Given this list of marker genes TERF2IP, CD300A, CDKN1C, LYN, TP53, DUSP7, TARBP2, PRKG1, PRKDC, RB1, PDCD4, PDGFB, SNX6, GIT1, KLHL31, DNAJC3, PTPRJ, ERRFI1, DBNDD2, STAT3, ZBED3, MVP, C9orf72, DDIT4, PARD3, RD3, AMDHD2, CDA (NCBI Gene Id 978), CEACAM1, IGFBP3, PDGFA, INPP5K, CDK5RAP1, SLC4A1, ZC3H12A, AKT1S1, VPS25, PARP1, IER3, NCOR1, WARS1, HIPK3, IQGAP1, MIR675, SOCS5, LPIN1, SFRP1, TRIM27, GSKIP, CDKN1A, SIRT2, INCA1, TFAP4, FKBP8, CORO1C, TSG101, PKIA, GMPPA, SOCS4, PRKCH, ADAR, RGS14, DYNLL1, PRR5L, DMTN, HNRNPU, CEP43, NT5DC2, PID1, SMO, HDAC4, YWHAG, RASIP1, PAQR3, TAF7, MACROH2A1, PTEN, PYCARD, NUPR1, INHA, CACTIN, AGT, ZGPAT, GADD45A, FBLN1, PTPRC, MAPK8IP1, EPM2A, PTPN13, ACTN3, SLIT2, PTPN22, AIDA, MEN1, PARP14, TSPO, INPP5F, GCKR, NIBAN1, TRAF3IP1, ATG14, NPPA, SFN, CHMP6 (charged multivesicular body protein 6), HEG1, CDK5RAP3, PIBF1, DEFB114, CDKN1B, SIRT1, CIB1, PPP2CA (protein phosphatase 2 catalytic subunit alpha), DRD2, SERPINB3, ABCA2, DNAJA1, PPP1R15B, NLRP2B, DUSP1, SRCIN1 (SRC kinase signaling inhibitor 1), NPRL2, ALDOB, MIR30C1, APOC1, FIS1, PTPN2, STK38, PPM1E, ITGB1BP1, FLCN, PGK1, CHP1, SFRP2, INHBA, PAK2, MYCNOS, ZFYVE28, TARDBP (NCBI Gene Id 81927), CDKN2A, PTPN1, SAMSN1, ANKLE2, CBFA2T3, CADM4, LPCAT1, ACP4, MIDN, PPIA, DEPTOR, ATP5IF1, URI1, TIGAR, SIRT6, RASSF2 (NCBI Gene Id 9770), PRKN, LATS1, NPM1, APOE, CEP85, IBTK, MTCH2, PPARA, PTK6, GSK3A, INSM1, GPRC5A, TRIM63, LATS2, PRDX3, ADIPOQ, FBP1, PRKACA, PLEK, ADARB1, RTRAF, PFKFB1, APC, THY1, CNKSR3, here is a description of the gene set: Any process that decreases the frequency, rate or extent of the chemical reactions and pathways involving phosphorus or compounds containing phosphorus. Human Gene Set: GOBP_NEGATIVE_REGULATION_OF_PHOSPHORUS_METABOLIC_PROCESS studied in species Homo sapiens